Given this list of marker genes CDH2, MX1, BBS5, BSN, RAB3A, TRAPPC11, TRAPPC2, LRRK2, RAB11A (NCBI Gene Id 8766), CSNK1D, EXOC8, KIF5B, SYNJ1, KIF1C, CADPS2, PRKN, TOR1A, TRAPPC8, BLOC1S5, KIF5A, SDC4, CHMP2A, EXOC6B, HGS, UNC13B, KIF1A, VPS4B, AP3M2, ARFGAP2, MREG, STXBP2, SNAPIN, SEC16A, MAP2, RAB7A, PSEN1, CUL3, SYN2, RAB27A (NCBI Gene Id 5873), TRAK2, BICDL1, MX2, KIF5C, SYT11, STXBP1, VPS33A (NCBI Gene Id 65082), AP3S2, LIN7A, MYO1C, NAGLU, SYT4, TESK1, AP1AR, UNC13A, AP3B1, FAM91A1, PINK1, MYO1A, SCRIB, AP3S1, PIK3CG, MYO5A, BRSK2, TRAPPC3 (trafficking protein particle complex subunit 3), BBS2, TRAPPC12, EXOC3, TRAPPC6B, SPG11, ACTN4, SNAP23 (NCBI Gene Id 8773), BLOC1S3, TMED10, MYO7A, PEF1, PAFAH1B1, TFG, STARD3NL (NCBI Gene Id 83930), KIF13A, TSG101, KIF28P, AP3B2, CHMP6, NLGN1, FYCO1, ATP9A, MKKS, CEP19, F8A2, KLHL12, BTBD8, PDCD6, F8A1, STXBP3, ARFGAP3, NDE1, DTNBP1, CTBP1, BLOC1S2, COPS5, SNAP25, SEPTIN5, RAB17, TRAPPC13, TRAPPC2B (NCBI Gene Id 51587), TMED9, F8A3 (coagulation factor VIII associated 3), ATP13A2, EXOC4, MAPK15, BORCS5, BBS7, RAB11B, DNM1 (NCBI Gene Id 1759), VPS33B, SNAP29, CHMP3, CCDC186, ARL6, CADPS (calcium dependent secretion activator), SDC1, SYNDIG1, KIF3B, WASL, CLASP1, PPFIA2, NLGN2, PDZD11, BLOC1S1, IFNG, LIN7B, TMED2, EXOC5, KIFC2, BLOC1S6, DNM3, STAM, ITGA4, TRAPPC5, UNC13C, AP3M1, WDR11, TRIP11, TRAPPC6A, NRXN1, CDR2L, SYBU, SHROOM2, BRSK1, USO1 (USO1 vesicle transport factor), TRAK1, TRIM46, SAR1A, DCTN2, TRAPPC4, TBC1D23, EXOC2, EXOC1, PCLO, HAP1, TRAPPC9, CLASP2, TRAPPC2L, EXOC7, IRAG2, RASGRP1, TMEM230, CDH3, KIF1B, TRAPPC1, SLC2A4, FNBP1L, SYN3, PPP6C, SYN1, KIFAP3, EXOC6, DYNC1I1, SAR1B, GPR143, AP1M2, BAIAP3, TPGS1, WIPI1 (WD repeat domain, phosphoinositide interacting 1), AP1G1, PTEN, LIN7C, RAB1A, SNF8, SDCBP (syndecan binding protein), ASIP, IKBKG, TANC2 (NCBI Gene Id 80259), MAP4K2, CDK5, DNM2, MAP2K1, CLN3, FBXW11, SMPD3, GBF1, BICDL2 (NCBI Gene Id 146439), PREB, YKT6, HTT, C17orf75, DCTN1, SNCA, KIF16B, LIMK2, TCIRG1, CTNNB1, BLOC1S4, KIF3A, STK11, AP3D1, PCDH17, PDCD6IP, NDEL1, MLPH, VPS4A, STARD3, TRAPPC10, here is a description of the gene set: studied in species Homo sapiens Human Gene Set: GOBP_VESICLE_LOCALIZATION Any process in which a vesicle or vesicles are transported to, and/or maintained in, a specific location.